Given this list of marker genes ROBO2, MEF2C, WNT11, SIX1 (NCBI Gene Id 6495), GDNF (glial cell derived neurotrophic factor), FGFR1, FOXH1 (NCBI Gene Id 8928), FGF8, TBR1 (T-box brain transcription factor 1), FGF10, FGF2, FGFR2, BMP4, FGF1, WNT2, DKK1, ISL1, GATA5, HOXC11, WNT2B, SPRY1, LRP2, GLI3, RBPJ, MESP1, POU5F1, PAX8, AXIN2, WNT5A (NCBI Gene Id 7474), ROBO1, EXT1, HOXA11, FRS2, AR, CTNNB1, BMP2, PAX2, SMARCD3, here is a description of the gene set: studied in species Homo sapiens Human Gene Set: GOBP_SPECIFICATION_OF_ANIMAL_ORGAN_IDENTITY The regionalization process in which the identity of an animal organ primordium is specified. Identity is considered to be the aggregate of characteristics by which a structure is recognized.